Given this list of marker genes Trarg1, Mapk8ip1, Inpp5b, Veph1, Rnf13, Rapgef1, Pnpla3, Lin54, Kcnk3, St3gal1, Vat1, Praf2, Ces3a, Cfl1, Zmiz2, Tbx4, Tomm40l, Sun2, Tal1, Cpa3, Ptprn, Map6, Gng4, Zfp592, Ntsr1, Chrm1, Klhl26, Chga, Fmod, Pml, Sec61a2, Ece1, Ehd3, Vash1, Pigm, Pdgfrb, Fev, Stard10, Tmem150b, Cd46, Lif, B3gat3, Zfp46, Becn1 (beclin 1, autophagy related), Mapk8ip3, Dvl3, Irf2bpl, Nptx1, Samd4b, Mboat4, Zfp384, Wscd2, D130043K22Rik, Slc7a5, Tmem80, Suv39h1, Foxp3, Nr5a1 (nuclear receptor subfamily 5, group A, member 1), Prr5, Arhgap36, Flrt1, Plk2, Cbfa2t3, Cs, Pde1b, Thbs3, Ptpru, Fbxo41, Arhgap1, Tlcd3b, Cluh, Cops6, Katnip, Mlx, Pom121, Uncx, Phldb1, Hyou1, Vamp2, Slc35f6, Cacfd1, Cdh16, Smg7, Foxp4, Ctif, Jrk, Znrf1, Lhfpl2, Smtnl2, Car7, Ppard (NCBI Gene Id 69050), Usp21, Iqsec2, Ehd1, Add1, Ccdc71l, Pip5k1c, Nckipsd, Map1a, Pax9, Zfp236, Adcy1, Chst4, here is a description of the gene set: Genes predicted to be targets of miRBase v22 microRNA mmu_miR_7048_5p in miRDB v6.0 with MirTarget v4 prediction scores > 80 (high confidence targets). studied in species Mus musculus from publication Chen Y, Wang X (PMID 31504780) Mouse Gene Set: MIR_7048_5P